The following is a description of a gene set: studied in species Homo sapiens Human Gene Set: GOBP_CHAPERONE_MEDIATED_PROTEIN_COMPLEX_ASSEMBLY The aggregation, arrangement and bonding together of a set of components to form a protein complex, mediated by chaperone molecules that do not form part of the finished complex., and this is the list of marker genes: DNLZ, MKKS, HSP90AB1, NDUFAF1, LONP1, BBS12 (NCBI Gene Id 166379), PSMG2, SPMAP2, CCT2, PSMG1, HOPX, PTGES3, HSPA4, HSP90AA1, BBS10, PSMG3, APCS, CLU, HSPD1, PFDN6, TMEM35A, HSPA1A, STUB1, PTGES3L